The following is a description of a gene set: Erythematous plaque A plaque (a solid, raised, plateau-like (flat-topped) lesion greater than 1 cm in diameter) with a red or reddish color often associated with inflammation or irritation. studied in species Homo sapiens Human Gene Set: HP_ERYTHEMATOUS_PLAQUE, and this is the list of marker genes: EBP, KRT10, MPDU1, CARD14, COL2A1, HAVCR2, AP1S3, SDHD, PTPN6, LDHA, TRPM4, MEFV, IL36RN, RASA1, COL7A1